The following is a description of a gene set: Any process that stops, prevents, or reduces the frequency, rate or extent of immature T cell proliferation. studied in species Mus musculus Mouse Gene Set: GOBP_NEGATIVE_REGULATION_OF_IMMATURE_T_CELL_PROLIFERATION, and this is the list of marker genes: Tmem131l, Erbb2, Bmp4, Ihh, Gnrh1, Cdkn2a, Clec4g